The following is a description of a gene set: part of: Chondroitin sulfate/dermatan sulfate metabolism studied in species Homo sapiens Reactome Pathway: CS-GAG biosynthesis Chondroitin sulfate (CS) glycosaminoglycan chains consist of N-acetylgalactosamine (GalNAc) residues alternating in glycosidic linkages with glucuronic acid (GlcA). They are bound to the tetrasaccharide linker moiety of core proteins like aggrecan, versican, or decorin. GalNAc residues are sulfated to varying degrees on 4- and/or 6- positions. The steps below describe the biosynthesis of a simple CS chain on a set of possible core proteins., and this is the list of marker genes: CSPG4, CHST15, CHPF, CHSY1, BGN, DCN, CHST9, CSGALNACT2 (chondroitin sulfate N-acetylgalactosaminyltransferase 2), VCAN, CHST11, CHST3, CHST13, CHST7, CHST12, CSGALNACT1, NCAN, CHSY3, CHPF2, BCAN, CSPG5, UST